The following is a description of a gene set: species: Mus musculus Any process that results in a change in state or activity of a cell or an organism (in terms of movement, secretion, enzyme production, gene expression, etc.) as a result of a stimulus indicating damage to the organism. Mouse Gene Set: GOBP_RESPONSE_TO_WOUNDING, and this is the list of marker genes: 5430416N02Rik, Mir16-2, F11, P2ry12, Rtn4r, Chl1, Fzd6, Selp, Bax, Rab3a, Trim72, Eppk1, Gata2 (NCBI Gene Id 14461), Alox15, Vangl2 (NCBI Gene Id 93840), Cfh, F13b, Ndnf, Comp, Hps1, Naglu, Map3k1, Yap1, Fn1, Tmem97, Mir26a-2, Il1rl1, Chmp3, F11r, Hmox1, Serpinf2, Myh9, Ddit3, Bloc1s3, Scrib, Pros1, Shh, Hnf4aos, Vkorc1, Wnt1 (wingless-type MMTV integration site family, member 1), Phldb2, Mirt2, Syk, Lrrc25, Nrep, Mertk, Matn4, 1810014B01Rik (NCBI Gene Id 66263), F3, Gm15645, Gnas, Bcl2, Fbxw10, Prrg2, Gna13, Myoz1, Dpysl3, Tlr4, Bex1, Notch2, Abhd2, Ctsg, Lyst, Pum2, Gipr, Serpind1, Ripor1, Nfib, Lyn, Plpp3, Fgl2, Emilin2, Duox2, Ptprf, Xylt1, Inpp5f, Mir17hg, Ins1, Pdia6, Angpt4, Ap3b1, F13a1, Reg3a, Ppara, Nlrp6, Prrg3, Apod, Hrg, Smpd1, S100a9, Itga5, Ceacam1, Prcp, Prrg1, Mir451a (microRNA 451a), F2rl2, Alox12, Anxa5, Chmp7, Itgb4, Ptn, Svep1, Cd151, BC028528, Dag1, Hif1a, Tpsab1, Mdk, Enpp4, Fgl1, Tmprss6, Tspan8, Kank1, Wfdc1, Pate4, Tspan32, Cldn4, Foxc2, Msx2, Plaur (plasminogen activator, urokinase receptor), Gp5, Cers2, Emilin1, Ocm, Clec7a, Sod1, Cx3cl1, Srsf5, Gp1bb, Nfatc1, Rab27a, Npr2, Pparg, Kcnk2, Pvt1, Rgma, Map2k4, Vps33b, Havcr1 (NCBI Gene Id 171283), P2ry1 (purinergic receptor P2Y, G-protein coupled 1), Fundc2, Sod2, Ednra, Mtr, Chmp5, Inhbb, Tnc, Apoh, Clec10a, Krt6a, Plg, Myof, Fga, Pik3cb, St3gal4, Ntrk3, Chmp2b (charged multivesicular body protein 2B), Ptger4, Timp1, Kdr, Tfpi2, Plet1, Tff1 (trefoil factor 1), Thbd, Epo, Alox5, Hc, Coro1b, Apoe, Col6a1, Gpr4, Mapk9, Pdgfa, Adra2b, Dsp, BC004004, Tlr3, F2, Map2k1, F7, Gip, Mir26b, Adra2a, Gp6, Il6ra, Actg1, Adamts18, Angpt1, Nppc, Pip5k1c, Gp9, Comt, Fbln1, Ccm2l (NCBI Gene Id 228788), Snhg17, Grhl3, Morn4, Matn2, Plec, Cd109, Fzd7, Pdia4 (protein disulfide isomerase associated 4), Dtnbp1, Pdia3, Sulf2, Vwf, Kcnb1, Tyrobp, Kremen1, Angptl6, Arhgap35, Rtn4rl1, Proc, Plcg2 (NCBI Gene Id 234779), Entpd1, Fkbp10, Foxa2, Epha4, Adam17, Arhgap24, Ddr2, Omg, Pcsk1, Anxa1, Elk3, Gap43, Fgf2, Ajuba, Ajap1, Scarf1, Il1a (interleukin 1 alpha), Gp1ba, Hpse, Hps6, Wnt5a, 4833427F10Rik, Stard13, Gata1 (NCBI Gene Id 14460), Mag (myelin-associated glycoprotein), Pdpn, Cav3 (NCBI Gene Id 12391), Mrtfa, F12, Hras, Casp7, Ptprj, Extl3, Erbb2, Lnpk, Rhoc, Ptpn6, Mapk8ip3, Angpt2, Syt7, Slc12a2, Apoa4, Thbs1, Gzmb, Nol3 (nucleolar protein 3 (apoptosis repressor with CARD domain)), Nf1, Tpm1, Enpp1, Rhoa, Jun, Ccl2 (NCBI Gene Id 20296), 2310075C17Rik, Klkb1 (NCBI Gene Id 16621), Cd24a, 3300005D01Rik, Dancr, Casp1, Mir22hg, F2rl3 (NCBI Gene Id 14065), Slc1a1, Trem2, Mpig6b, Zfp36l1, Serpinc1 (NCBI Gene Id 98260), Gm10791, Prkca (NCBI Gene Id 18750), P2rx1, Mcam, Braf (Braf transforming gene), Mmp12, Nfix, Fcer1g, Lrp1, Grn, Klf4, Nefh, Chmp4b, Celsr1, Adtrp, Mir20a, Arl8b, Pdgfra, Mir106a, Prdx2, Ctnna1, Cldn19 (NCBI Gene Id 242653), Ccn4, Cpb2, Il33, Chmp2a (NCBI Gene Id 68953), Cd36, Epb41l4b, Muc16, Mmp2, Ppl, Nmnat1, Aqp1, Itgb5, Pak1, Gm12610, Angptl1, Cd9, Ppia, Ccn1, Itpr3, Nfe2l2, Foxf1, Nbeal2, Fgb, Nfia, Gpx1, Nrp1, Fgf10, Arfgef1, Mmrn1, Fermt3, P2rx4, Cldn13, Dmtn, Mfsd2b (NCBI Gene Id 432628), Naip2, Map2k7, Hmga1, Atp7a, Tnfrsf12a, Slc1a3, Macf1, F8, Ptk7, Rasa3, Slc1a2, Evl, Vash1, Grin2a, Tmeff2, F2r (NCBI Gene Id 218465), A330069E16Rik, Rtca, Siglecg, 1700123M08Rik (NCBI Gene Id 76665), Sdc4, Arhgef19, Col3a1 (NCBI Gene Id 98713), Stat3, Clasp2, Igf1r (NCBI Gene Id 77773), Chmp1a, Map2k2, Gla, Mylk, Sarm1, 2210409D07Rik, Prkcq, Gli1, Col5a1, Vegfa (NCBI Gene Id 22339), Ubash3b (NCBI Gene Id 72828), Srsf6, Plek (NCBI Gene Id 69998), Ins2, Mir26a-1, Nmnat3, Tmprss4, Casp3, Itgb1, Lamb2, Smad3, Lrig2, Tspo, Pou2f3, Map1b, Ppard, Slc11a1, Prf1, Angptl2, Slc4a1, Tsku, Cd34, Gnaq, Dst, F5, Stxbp1, Rreb1, 5730416F02Rik, Scnn1g, Duox1, Entpd2, Mia3, Slc7a11, Ext1 (NCBI Gene Id 14042), Scnn1b, Tfpi, Bloc1s4, Adra2c, Wdr83, Jak2, Ddr1, Kng2, Dcbld2, Bnip3, Drd5, Lcp1, Cd44, Max, Myh10, Tmx1, Dsg2, Wnt3a, Cav1, Mirt1, F9, Chmp6, Dysf, Gsdmd, Tbxa2r, Prss56, Eng, Cdkn1a, Cxadr, C1galt1c1, Fgf1, Wnt7a, Axl, Nog, Cd2ap, F10, Rtn4rl2 (NCBI Gene Id 269295), Mir494, Itgav, Bnc1, Odam, Fosl1, Ndel1, Prrg4, Mtor (NCBI Gene Id 80612), Tafa5, S100a10, Hmga2-ps1, Jaml, Evpl, Stxbp3, 2310040G24Rik, Anxa8, Ecrg4, Ubash3a, Sh2b3, Ephb2, Vps4b, Vil1, Ccr2, Pten, Hgfac, Drd2, Sox2, Syt11, Tnf, Cdk1, Zfp36l2, Pecam1, Cnn2, Fermt2, Acvrl1, Neo1, Gata4, Ptprs, Flna, Procr, Hbegf, Cadm4, Hnf4a, Fgfr3, Anxa2, Aurka, Vtn (NCBI Gene Id 22370), Il17a, Proz, Ntrk1, Cldn3, Snai2, Hmgb1, Tgfb1, Plau, Lrg1, Flrt3, Mrln, Cd40lg, Hps4, Mir20b, Itgb6, Itgb3, Serpine1, Apoa1, Nfkbiz, Hps5, Pdgfb, Fgg, Cela2a, Insl3, B4galt1, Prr33, Fgfr1op2, Mir16-1, Tnfaip3, Speer5-ps1, Txn2, Prkcd, Gas6, Rangap1, Serpina10, Igf1, Adipor2, Cflar, Carmil2 (capping protein regulator and myosin 1 linker 2), Tnr, Treml1, Sytl4, Lilrb4a, Pard3, D130043K22Rik, Pf4, Pdcd10, Plat, Rap2b, Srf, Fntb (NCBI Gene Id 70263, farnesyltransferase, CAAX box, beta), Tspan9, Zfp36, Ptk2, Xbp1, Tor1a, Nrg1, Pdia2, Prkg1, Dhfr, Psg23, Pax6, Kng1, Bloc1s6, Snhg15, Folr1, Fermt1, Cask, Angptl4, Vps4a, Prkce, Tubb1, F2rl1 (NCBI Gene Id 14063), C1qtnf1, Cldn1, Serpine2, Il6, Eldr (Egfr long non-coding downstream RNA), Pear1, Slc6a4, Htr2a, Papss2, Nr3c1, Cspg5, Gkn2, Vegfb, Ndufs4, Stk24, Ndp, Fer1l5, Ano6, Smoc2, Clasp1, Klk8, Tyro3, Tgfb2, 2810403D21Rik, Tec, Reg3g, Mir17, Nefl, AI506816 (expressed sequence AI506816), Chmp4c, Fkbp1b, Pla2g4a, Mir106b, Cxcr4, Angptl7, Mir338, Wnt4, Ano5, Git1, Chmp1b, Chmp1b2, Mir3065, Grin2c, Adamts13, Neat1, Crk, Serping1, Il10, Cntf